Given this list of marker genes Park7, Fn1, Pgam2, Slc39a8, Slc34a1, Aqp2, Aqp1, Abcc2, mt-Cytb, Tat, Gatm, Alad, Bsg, Slc1a1, here is a description of the gene set: species: Mus musculus Mouse Gene Set: GOBP_RESPONSE_TO_MERCURY_ION Any process that results in a change in state or activity of a cell or an organism (in terms of movement, secretion, enzyme production, gene expression, etc.) as a result of a mercury ion stimulus.